Given this list of marker genes LLGL2, SLC7A7, SLC6A17, SLC43A2, SLC7A5, SLC7A6, SLC6A15, SLC43A1, SLC3A2, SLC7A8, here is a description of the gene set: Human Gene Set: GOBP_L_LEUCINE_TRANSPORT The directed movement of L-leucine, 2-amino-4-methylpentanoic acid, into, out of or within a cell, or between cells, by means of some agent such as a transporter or pore. studied in species Homo sapiens